The following is a description of a gene set: from publication Ramirez K, Chandler KJ, Spaulding C, Zandi S, Sigvardsson M, Graves BJ, Kee BL (PMID 22608498) Expression profiling of Rag2-deficient Ets1++ and Rag2-deficient Ets1-- mature NK cells and WT bone marrow progenitors, WT T cells, and WT Pro B cells Human Gene Set: GSE37301_CD4_TCELL_VS_RAG2_KO_NK_CELL_UP studied in species Homo sapiens Genes up-regulated in CD4 T cells versus RAG2 knockout NK cells., and this is the list of marker genes: TRIM9, EFCAB7, DSCAML1, BDNF, HDAC1, INA, ITPRIPL2 (ITPRIP like 2), CD79A, PRSS12, SLC25A53, EGLN3, FBXL18, GPATCH11, B3GALT5, KCTD3, RGS9 (regulator of G protein signaling 9), B4GALNT4, CHIC1, MIR15A, CIBAR1, SLC45A1, PPFIBP1, PDCD1, KLK12, GCNT1, PTPRS, GZMK, SPRY4, MID2, CNTNAP1, SLC15A3, FNIP2, CEP162, ICOS, DCTD, ECRG4, CYP7A1, PLSCR4, STK32C, GFOD2, MIR299, HS3ST1, RAB8B (RAB8B, member RAS oncogene family), GPR55, GNB5, EMB, NAV1, PTPN13, GALR1, RNF43, RNF11, NEK6, TTC14, MIR135B, RORA, MEP1A (NCBI Gene Id 4224), TNFSF14, ERLIN1, OAF, STX6 (NCBI Gene Id 102724791), SLC16A4, SUSD2, TTC9, HELLS, HMGB3, SMARCE1, ERO1A, ANKS6, CATSPERD, PTGER2, MIR32, PLOD2, JAG1, GPX2, SLAMF6, EPDR1, CXCL10, TEDC1, SRMS, CISH, DCN, TOX2, STK39 (serine/threonine kinase 39), CALML4, AOC1, UBXN8, IFIT3, NEBL, CER1, FSD1L, ZC3H12C, ST6GALNAC5, RYK, DSE, SPMIP2, OSBPL6, UNC13B, TEKT5, TNFSF8, MAFG, CDC42BPB, ATAD5, LECT2, ROBO1, NKG7, CCDC157, LRFN2, RBFOX2, SEMA6D, IL18RAP, TEX9, UPK1A, SCPEP1, AVPR1A, DCBLD2, WDTC1, TTYH2, CD34, ADAM8, TRPM6, SLC25A46, SCP2, C1orf174, CDK6, E2F6, AHR, MIR500A, IL18R1, EBI3, CCDC112, CDK15, KCNK6, CCL5 (NCBI Gene Id 8147), USHBP1, ZC3H8, SAXO4, ACYP1, ATP10A, HMGN3, TNFSF13B, PLCB4, TPRN, SPRED3, PLCD1, CANX, HDLBP, NAV2, SKA2P1, ZC2HC1A (NCBI Gene Id 51101), SMOC2, TPH2, TNFSF11 (TNF superfamily member 11), CACYBP, SCIN, RGMB, FUBP1, ADAMTSL2, SPEF2, NHLH1, KIF20B, GPR171, MIR216A, TMBIM1